The following is a description of a gene set: part of: Signaling by FGFR Reactome Pathway: Signaling by FGFR2 species: Homo sapiens The 22 members of the fibroblast growth factor (FGF) family of growth factors mediate their cellular responses by binding to and activating the different isoforms encoded by the four receptor tyrosine kinases (RTKs) designated FGFR1, FGFR2, FGFR3 and FGFR4. These receptors are key regulators of several developmental processes in which cell fate and differentiation to various tissue lineages are determined. Unlike other growth factors, FGFs act in concert with heparin or heparan sulfate proteoglycan (HSPG) to activate FGFRs and to induce the pleiotropic responses that lead to the variety of cellular responses induced by this large family of growth factors. An alternative, FGF-independent, source of FGFR activation originates from the interaction with cell adhesion molecules, typically in the context of interactions on neural cell membranes and is crucial for neuronal survival and development.<br><br>Upon ligand binding, receptor dimers are formed and their intrinsic tyrosine kinase is activated causing phosphorylation of multiple tyrosine residues on the receptors. These then serve as docking sites for the recruitment of SH2 (src homology-2) or PTB (phosphotyrosine binding) domains of adaptors, docking proteins or signaling enzymes. Signaling complexes are assembled and recruited to the active receptors resulting in a cascade of phosphorylation events.<br><br>This leads to stimulation of intracellular signaling pathways that control cell proliferation, cell differentiation, cell migration, cell survival and cell shape, depending on the cell type or stage of maturation.<br>, and this is the list of marker genes: POLR2J, POLR2K, FGFR2, POLR2B, FGF17, RPS27A (NCBI Gene Id 6233), FGF9, PIK3R1, POLR2E, GAB1, SHC1, POLR2F, TIA1, FGFR2c, FGF8, CBL, FGF4, POLR2D, FGFBP3, POLR2G (RNA polymerase II subunit G), RBFOX2, FGFR2b, FRS2, FGF2, FGF6, FGF1, POLR2A, PPP2CB, FGFBP2, HNRNPM, FGF16, UBA52, GTF2F1, KRAS, SRC, PPP2CA, GTF2F2, FGF23, PPP2R1A, NCBP2, MKNK1 (NCBI Gene Id 8569), FGF5, NRAS, ESRP1, FRS3, TIAL1, POLR2C (NCBI Gene Id 5432), SOS1, ESRP2, HRAS, SPRY2 (NCBI Gene Id 10253), MAPK1, BRAF, UBC, HNRNPH1, POLR2I, POLR2L, HNRNPF, GRB2, HNRNPA1, PIK3CA, UBB, PLCG1 (NCBI Gene Id 5335), FGFBP1, FGF3, NCBP1, POLR2H, FGF7, FGF20, FGF10, FGF22, MAPK3, PTBP1, PTPN11, FGF18